Given this list of marker genes ROS1 (ROS proto-oncogene 1, receptor tyrosine kinase), GPR182, CD5L, GPR65, CD79B, IL18R1, CR2, PGLYRP1 (peptidoglycan recognition protein 1), PDK1, FOLR1, MUSK, TNFSF11, TNFRSF25, CXCR2, TNFRSF17, CD5, CD40, PLPP2, CHRM1, FCER1A, RGR, PDK4, CD6, P2RY6, CHRNB1, CILP, FCER2, CHRNA7, GRPR, EPHB1, IL12A, HLA-B, APOH, PRKCA, HLA-DRB5, ITGAL, TNFRSF10A, FZD5, IFNGR1, OPRK1, KLRC2, SFRP4, CD2, CRLF1, FZD2, FGFR3, GPRC5A, FRZB, TNFRSF21, P2RY14, GPLD1, NGFR, CSF2RA, PTGER1, F3, CD4, CD72, IGLL1, FAS, EFNB3, GLRA3, S1PR2, RORA (RAR related orphan receptor A), IL2RB, GPRC5B, PTPRO, SELP, KLRK1, FPR1, HCRTR2, CNR2, KIR2DL4, GRM3, EPOR, IL1RAP, AGTR1, DRD4 (NCBI Gene Id 1815), GLRA1, TNFRSF11B, TNFRSF13B, ASGR1, EPHA7, ADGRE1, ROR1, MERTK, OPCML, FGFR1, HFE, UNC13B, MYOC, CD8B, LILRA2, FCGRT, KLRC4, CCR5, EVI2A, HTR2B, THBD, FCGR3A (Fc gamma receptor IIIa), IL2RA, TRIB2, NPR3, IL2RG, FOLR2, GHR, IL7R, PLAUR, ITGB8, PDGFRA, CHRNB2, CLDN4, CCR2, LILRB2, HTR4, C3AR1, NR2F1, PTPRR, ITGAM, RRH (NCBI Gene Id 10692), PTPRS, NPY (NCBI Gene Id 4852), CD27, PLA2R1 (NCBI Gene Id 22925), PDGFRL, EDNRB, LEPR, SLAMF1, HYAL2 (NCBI Gene Id 8692), CIITA, TACSTD2, ASGR2, IL15RA, NR0B2, PDGFRB, PRKD1, CD69, GPA33, PTPRC, GHRHR, HLA-DMB, FLT3, GABRE, BDKRB1, CD3G, BRS3 (bombesin receptor subtype 3), LGALS3BP, ITGAX, EFNA4, IL12RB1, IL6ST, LILRB3, RARG (retinoic acid receptor gamma), KIR3DL1, ADCYAP1R1, GRM2, GPR183, MS4A2, VDR, TLR1, NCR1, IL4R, GFRA3, PPARG, AXL, PTH1R, LRP1, IL10RA, PRB4, ADORA2A, CD163, TGFBR3, ITGB7 (NCBI Gene Id 3695), GPR39, EPHA4 (NCBI Gene Id 401031), CD180, CD3D, ICAM1, NPR2, HTR3A, FZD9, ITGB6, CD14, CDK5R1, GPR37L1, PTPRG, LILRA1, ERBB4, TIRAP, PPARA, GRIN1, PTPRH, CHRNA4, KIR2DL3 (NCBI Gene Id 51344), PTPRN2 (protein tyrosine phosphatase receptor type N2), GABRB3, BMPR1B, P2RX3, BDKRB2, OXTR, NRP1, KIT, CHRNE, RARA, IGSF6, MST1R, CD300C (CD300c molecule), LDLR, P2RY10 (P2Y receptor family member 10), KLRC1, ROR2, PRPH2, ITGA9, P2RX1, RAMP3, PTPRF, C5AR1, GP1BB, CNR1 (cannabinoid receptor 1), LPAR6, ITGA5, CD86, LTBR, HLA-DOA, HLA-C, CCL2, GP1BA, CR1, NPY1R, CCR9, MRC1, GABRP, GABRG2, CX3CR1, GRIK1, TEK, CD80, NTRK2, SEMA4D, CD96, PSG3, IL13RA1, AR, FPR2, ITGA3, NPY2R, GPR75, EDNRA, CCR8, PTGFR, GRIK2, LILRA3, ANPEP, CXCR6, TIE1, ADRB2, ADRA2B, CCL13 (NCBI Gene Id 6357), HBEGF, CFI (complement factor I), HLA-DRA, FOLR3, PTPRM, LANCL1, RARB, IL3RA, LGALS3, GABRG3, TNFRSF1B, OPRM1, CHRNB4, FGFR2, VIPR1, GPR171, AHR, ADORA3, PRKCH, FCGR1A, CNTFR, PTH2R, EPHB2, HLA-A, AVPR1A, CD79A, ITGB2, CALCRL, IL6R, IL1R1, CNTNAP1, FCAR, HRH1, GABRR1, CHRNA2, FCER1G, PTPRE, TLR3, B2M, PTAFR, CDKN1A, MPL, TNFRSF8, HCP5, CXCR4, PTGER2, LRP2, CCR1, ACKR1, TACR3, CHRNA3, ADGRB2, ITGB3, PRSS12, HCAR3, LIFR, RYR1, EPHA2, NR4A2 (nuclear receptor subfamily 4 group A member 2), CD247, DDR2, GRIK3, LPAR1, ADRB1, ADGRL2, CSF3R, CD8A, CSF2RB, GLYAT, LILRB4, ITGB5, ITGA10, FCGR2A, TNC, MCC, EPHB6, TMPRSS2, PTK7, CXCR5, NTSR1, GLRA2, RNASEL, HLA-G, IL13RA2, ERBB2, EFEMP2, ADRA2A (NCBI Gene Id 92480), TNFRSF4, TMPRSS15, GALR3, CHRNB3, IL27RA, RXRA (retinoid X receptor alpha), DRD3, ADORA1, OLR1, TLR2, ITGA2B, here is a description of the gene set: species: Homo sapiens Human Gene Set: MODULE_27 Genes in the cancer module 27.